Given this list of marker genes HBB, LAS1L, HDAC8, NSMCE2, CTDP1, NBN, XRCC4, here is a description of the gene set: Malar prominence Human Gene Set: HP_MALAR_PROMINENCE species: Homo sapiens Prominence of the malar process of the maxilla and infraorbital area appreciated in profile and from in front of the face.